Given this list of marker genes Cd79b, Btrc, Skint6 (NCBI Gene Id 230622), Cd79a, Ermap, Dennd1b, Cd276, Oas1b, Cyba, Grb2, Ada, Prkd2, Braf, Ubr2, Cyld, Rela, Dusp22, Vav3, Laptm5, Ticam1, Themis3, Cacnb4, Pde4b, Mapk1, Stap1, Elf1, Hmgb1, Rc3h1, Klrk1, Klrc3, Klrd1, Ticam2, Skint11, Shb, Khdrbs1, Cmklr1, F2rl1, Eif2b3, Sh2d1b1, Lgals3, Gps2, Bag6, Rftn1, Ecsit, Kit, Itgam, Stoml2, Syk, Bmx, Pja2, Fcer2a, Lat, Skap1, Ffar2, Nr1h3, Lilrb4a, Btnl9, Fcho1, Tnip2, Btnl2, Wdfy1, Itk, Bcl10, Ninj1, Eif2b1, Gcsam, C3ar1, Prkce, Clec4e, Klre1 (killer cell lectin-like receptor family E member 1), Klri1, Fcna, Rab11fip2, Ptpn22, Tec, Skint9 (selection and upkeep of intraepithelial T cells 9), Btnl10, Pik3ap1, Ctla4, Cd22, Rap1a, Ceacam1, Oas1h (2'-5' oligoadenylate synthetase 1H), Skint7, Lck, Zfp683, Fpr-rs6, Ifng, Tax1bp1, Prkcb, Phpt1, Prkch, Rnf31, Ptprj, Tnfrsf21, Foxp3, Cd14, Blnk, Nr1d1, Tril, Skint8, Vtcn1 (NCBI Gene Id 277633), Skint4, Plscr1, Cd300a, Dusp3, Blvra, Rab29, Stk11, Plcg2, Btnl6, Pawr, Zap70, Ptpn2, Ikbkg, Fcer1g, Gpr33, Cd8b1, Sos1, Trat1, Naglu, S100a14, Oscar, Cd247, Thy1, Foxp1, Cd8a, Gata3, Rab7b, Pten, Nr4a3, Fpr-rs3, Tlr2, Bcl2, Rc3h2, Card11, Mbl2, Acod1, Btn1a1, Slc39a6, Oas1g, Nfkbiz, Fyb2, Btnl12, Fpr3, Oas1a, Traf6, Fcgr3, Btla, Oas1f, Fpr2, Eif2b4, Cd38, Btk, C3, Fosl2, Nod2 (nucleotide-binding oligomerization domain containing 2), Skint3, Irak1, Nfam1, Lax1, Fcer1a, Ighm, Txk, Sh2b2, Tlr4, Fcgr1, Bpifb1, Mfhas1, Lrrfip2, Tmem126a, Carmil2, Tlr1, Fcnb, Usp12, Ighe, Appl1, Klhl6, Usp46, Psen1, Plscr2, Ifi35, Peli1, Lipa, Btnl1, Vav1, Clec4n, Eif2b5, Rabgef1, Nras, Plcg1, Bcar1, Ptpn6, Lpxn, Lime1, Mef2c, Ubash3a, Cblb, Pram1, Cmtm3, Btn2a2, Plekha1, Klrc2, Tnfaip3, Trav7-2, Cacnb3, Tbk1, Irf3, Cd2ap, Clec7a, Pik3r1, Sqstm1, Cd40, Skint2, Oas1c, Sppl3, Blk, Cd3e, Rapgef1, Lcp2, Ms4a1, Eif2b2 (eukaryotic translation initiation factor 2B, subunit 2 beta), Kcnn4, Scimp, Znrf1, Clec4d, Lyn, Tespa1, Nfkb1, Pde4d, Rps3, Rbck1, Cd19, Trem2, Ltf, Cd28, Cr2, Tlr6, Themis2, Itpripl1, Fpr-rs4, Icosl, Oas1e, Ezr, Skint10, Dgkz, Nfatc2, Clec12b, Skint1 (NCBI Gene Id 639781), Pvrig, Crkl, Letmd1 (LETM1 domain containing 1), Usp9x (ubiquitin specific peptidase 9, X chromosome), Skint5, Mog, Lbp, Ly96, Map3k7, Fyn, Abl1 (NCBI Gene Id 98922), Tirap, Ptprc, Irak2, Themis, Fyb1, Fcmr, Oas1d, Sh2d1a (SH2 domain containing 1A), Gpld1, Slc39a10, Hras, Klri2, Lat2, Cd81, Tnip3, Fcgr4, Nfkbid, Nmi, C5ar2, Pigr, C5ar1, Nos2, Malt1, Vav2, Plcl2, Fpr-rs7, Arf6, Klrc1, Nfkbia, Tyrobp, Zc3h12a, Dab2ip (NCBI Gene Id 98996), Ccr7, Cd160, Psen2, Cd226, Bax, Fpr1, Trim32, Fcrl5, Ncr3-ps, Traf3, Tlr5, Myd88, Prnp, Btnl4, Nectin2, Ube2n, Nck1, Sla2, Clec2i, Lilrb4b, Fer, Wnk1, H2-M3, Bcl2a1d, Appl2, Ripk2, Cd47, Csk, Nckap1l, Myo1g, Chuk, here is a description of the gene set: The series of molecular signals initiated by an extracellular ligand binding to a receptor on the surface of the target cell capable of activating, perpetuating, or inhibiting an immune response. Mouse Gene Set: GOBP_IMMUNE_RESPONSE_REGULATING_CELL_SURFACE_RECEPTOR_SIGNALING_PATHWAY species: Mus musculus